The following is a description of a gene set: Mouse Gene Set: GOBP_REGULATION_OF_PROTEIN_TARGETING_TO_MITOCHONDRION studied in species Mus musculus Any process that modulates the frequency, rate or extent of protein targeting to mitochondrion., and this is the list of marker genes: Gsk3a, Nol3, Bnip3l, Pdcd5, Bag3, Parl, Siah3, Prkaa1, Fbxw7, Tomm7, Bag4, Ptpn5, Hspa1l, Adcy10 (NCBI Gene Id 73777), Tomm70a, 4930550C14Rik, Lrrk2, Cdkn2a, Srebf1 (NCBI Gene Id 276754), Atp5if1, Pink1, Pdcd5-ps